Given this list of marker genes AFF4, LMNA, FKBP6, GATA4, SLC2A10, RAB3GAP2, TBL2, RPL3L, MT-TW, VPS33A, RET, HBA2, APOA1 (NCBI Gene Id 335), ADCY5, FLNA, XYLT1, HFE, MT-CYB, GTPBP3, ALPK3, COL1A1, LTBP1, GTF2IRD1, CITED2, ELN, STRADA, SDHC, SDHB, MT-TC, FGD1, FBN1, LAMA4, CASR, SLC19A2, SDHD, HJV, NSMCE2, HAMP, RBCK1, CAVIN1, TRIM37, EYA4, RPS19, PPA2, CLIP2, RAF1, ACAD9, MYZAP (NCBI Gene Id 100820829), FHL2, CSRP3, RFC2, ACTC1, TCF4, CLIC2, TNNI3K, JPH2, MT-TV, ENPP1, RBM20, EPAS1, PLN, STX1A, TTN, HLA-DRB1, ENG, PPCS, GNPTAB, BCHE, LDB3, ADAMTSL2 (NCBI Gene Id 9719), MT-CO1, IFIH1, ATP6V1A, FLII, MYBPC3, AGGF1, TNNI3, STAT1, BUD23, BSCL2, HAND2, CAV1, LYZ, SCO2, EFEMP2, COL1A2, HNRNPA1, MT-TF, GTF2I, MT-TQ, PTEN, TF, HADHB, PSEN2, DNMT3A, ANKRD1, CRYAB, IKBKG, KCNJ5, WRN, TNNT2, PPARG, GNA11, TMEM43, DOLK, ATXN7, SCN1B, CHD6, MLX, GAA, FGFR3, GLA, DSG2, GET3, LIMK1, BAZ1B, TUBB, ELAC2, TFAM, AGPAT2, MYD88, XYLT2, RRAGC, CCR6, MST1, BMP2, KIF1B, IL36RN, SLC25A26, MAX, TMEM270, ATP5F1A, PEX7, MT-CO2, SCN4A, NDUFAF1, PHYH, MYSM1, MT-ND5, HNRNPA2B1, VCL, FOS, GPR35, TCAP, PDE11A, IRF5, MT-TL1, IL12B, TAF1A, BAG5, MECP2, VHL, SDHA, DOHH, KCTD1, HADHA, CCN2, TAFAZZIN, EPHB4, SEMA4D, ACVRL1, MYH6, MYH7, MT-ND1, TXNRD2, VPS37D, SGCA, GATAD1, DSP, CAV3 (caveolin 3), MT-CO3, FKTN, ABCC9, NEXN, NF1, TPI1, TMPO, IL6ST, LMOD2, SMARCAL1, COG7, DMD, FBLN5, AP1S3, NCF1, CAP2, MT-TS2, SDHAF2, GATA6, DLST, TLL1, ACTN2, PIK3CA, METTL27, HLA-B, TRPM4, ABCC6, CACNA1S, MRPL39, RASA1, GDF2, SCO1, GLB1, COX16, HBB, PNPLA2 (NCBI Gene Id 57104), TBX20, EIF4H, MAPRE2, MT-TK (NCBI Gene Id 4566), MYL3, CEP19, SLC22A5, CP, PRKAG2, BMP6, TTR, DTNA, LAMP2, SGCD, FH, DES, MYPN, MYLK2, VCP, SLC25A3, PSMB8, NDUFB11, GTF2IRD2, AARS2, SNAP29, MDH2, CLPB, SCN5A, MT-ND6, SMAD4, FLNC, CDH23, ALMS1, TNNC1, EPG5, PSEN1, SF3B1, TRIP4, IDS, VEZF1, SLC17A5, TPM1, MTTP, HBA1, NKX2-5, DNAJC19, DNAJC30, TMEM127 (transmembrane protein 127), RYR1, NPPA, BAG3, TAB2, TMEM70, JUP, PRKAR1A, FXN, TET2, LRPPRC, SELENON, ALDH18A1, PLOD1, SPTBN1, SLC25A11, PRDM16, here is a description of the gene set: The presence of an abnormality of cardiac function that is responsible for the failure of the heart to pump blood at a rate that is commensurate with the needs of the tissues or a state in which abnormally elevated filling pressures are required for the heart to do so. Heart failure is frequently related to a defect in myocardial contraction. Human Gene Set: HP_CONGESTIVE_HEART_FAILURE species: Homo sapiens Congestive heart failure